Given this list of marker genes Edn1, Rap1gds1, Cdc42, Ramp3, Chga, Ednra (NCBI Gene Id 14737), Rac1, Pln, here is a description of the gene set: studied in species Mus musculus An G protein-coupled receptor signaling pathway which contributes to a circulatory system process carried out by the heart. Mouse Gene Set: GOBP_G_PROTEIN_COUPLED_RECEPTOR_SIGNALING_PATHWAY_INVOLVED_IN_HEART_PROCESS